The following is a description of a gene set: from publication Szanto A, Balint BL, Nagy ZS, Barta E, Dezso B, Pap A, Szeles L, Poliska S, Oros M, Evans RM, Barak Y, Schwabe J, Nagy L (PMID 21093321) Human Gene Set: GSE16385_ROSIGLITAZONE_IL4_VS_IL4_ALONE_STIM_MACROPHAGE_12H_DN studied in species Homo sapiens Genes down-regulated in macrophages (12h): rosiglitazone and IL4 versus IL4. Human CD14 positive monocytes were purified from healthy volunteers’ blood and cultured in vitro for 4, 12, 24, 72 hours. While culturing, macrophages were activated alternatively with interleukin-4 (IL-4 100 ng/ml) or classically with interferon-gamma (IFNg 100 ng/ml)+tumor necrosis factor (TNF 50 ng/ml) or left without activation. Simultaneously, macrophages were also treated with vehicle (DMSO:ethanol) or 1mM synthetic PPARg agonist, Rosiglitazone. We used Affymetrix microarrays (U133Plus 2.0) to analyze activation and PPARg-induced gene expression changes., and this is the list of marker genes: VAV3, LITAF, CORO1B, HSD17B8, GCLC, YBX3, ANXA1, GABRG3, ZMYM1, NDST3, MLEC, MT2A, FKTN, ASB9, TMEM183A, SNX10, TASP1, CTSG, TCEAL4, GIMAP6, RABIF, JADE3, IFNGR2, PRPSAP1, GPD1L, HGSNAT, TRAF3IP2, SCN3A, ABCC4, OAS3, HPGDS, DHCR7, TARP, FADS1, CTNNBIP1, E2F6, ZNF667, NUFIP1 (nuclear FMR1 interacting protein 1), CHST12, NCF4, LIMS1, F8, FAH (NCBI Gene Id 2184), PGM1, LPAR6, UGDH, TTC27, IGF1R, LCT, PKIG, ACACA, MREG, SUPT3H, SPAG1, APOOL (apolipoprotein O like), CLDN5, GUCY1B1, CANT1, MFAP4, ERI3, ZNF395, CLIC4, NEDD4, GNAQ, RUNX1, FAM168A, DHRS11, LIMA1, PLS3, HES1, RCBTB2, MDFIC, OPA1, FTO, IMPACT, TES, TST, PRSS3, MYO5C, G6PC3, P4HTM, SPINK2, CLIP3, SPON2, MME, PDIA5, WDR41, MXRA7, PRR3, CASP1, PTPRD, TMSB10, GAB2, TLR1, SCHIP1, GMDS, HOXA5, GNPDA1, ABCA1, MAN1A1, GNPTAB, RGS19, ARMCX2, C1orf54, RPE65, RNF144A (ring finger protein 144A), B4GALT6, TNFAIP2, ANAPC13 (NCBI Gene Id 25847), TGIF1, AP2B1, SOCS6, PTP4A1, GTF3C2, SERPINB1, ADGRA3, CDADC1, RNF130, ELMO1, PTGER2, SERPING1, CREB3L2, XYLT1, AP1AR, LYZ, ISYNA1, IGF2BP2, ARHGAP5, FZD6, ERCC1, ORAI3, ARHGAP17, ZNF208, FOS, GATAD2A, KL, ZNF189, ATP9A, GATM, UTRN, PECAM1, POGLUT2, CSGALNACT1, PDE6C, SRBD1, CTNND1, DNAJC12, DENND5A, SH3BP4, PCTP, NUDT11, TTLL1 (TTL family tubulin polyglutamylase complex subunit L1, NCBI Gene Id 25809), IGLL1, ZMIZ1, IGFBP6, SELL, TFPI, KANK1, PRUNE2, SMARCD1 (NCBI Gene Id 6602), MAP4K3, DNMT3B, RPL10L, STAT4, BAZ2B, DVL3, CYP2E1, PFKM, CLEC11A, CCDC92, RIMS3, RAP1GAP2, ZMYM4, SAMSN1, WASF1, GLB1, TNFSF4, RRAS2, KLF10, CASD1, PLAC8, BCL2L2, JCHAIN, CR2, ARMCX1, YLPM1, RPP40, MOCS2, DPYD, EIF4EBP1, HIBCH, SLC25A13, SERINC5, SOCS2, AFAP1, RAB13, ANXA4, HK2, RPL41, CD300A